Given this list of marker genes THRA, VDR, NR2C2, NR6A1, ESRRA, NR2E3, HNF4A, here is a description of the gene set: Nuclear receptors whose expression correlated with that of aromatase (CYP19A1) in a panel of breast cancer biopsies. species: Homo sapiens Human Gene Set: MIKI_COEXPRESSED_WITH_CYP19A1 Aromatase is a key enzyme in intratumoral estrogen production required for the production of estrogens through the conversion of serum androgens in postmenopausal breast cancer patients. There have been, however, controversies regarding the intratumoral localization of aromatase in human breast carcinoma tissues. Therefore, we have first examined the intratumoral localization of aromatase mRNA/protein in 19 breast carcinomas using laser capture microdissection/quantitative reverse transcription-PCR (RT-PCR) and immunohistochemistry. Aromatase mRNA and protein were detected in both intratumoral stromal and parenchymal cells in breast carcinoma tissues. Subsequent microarray expression profiling and clustering analyses, in addition to quantitative RT-PCR studies, showed a significant positive correlation between aromatase and estrogen-related receptor alpha mRNA expression in isolated carcinoma cells. We further examined an interaction between stromal cells isolated from human breast carcinoma tissues and breast carcinoma cell lines using a coculture system to study the biological characteristic of aromatase expression in carcinoma cells. Aromatase mRNA and enzyme activity and 17beta-hydroxysteroid dehydrogenase type 1 mRNA in breast carcinoma cell lines, including MCF-7 and SK-BR-3 cells, were up-regulated in the presence of patient-derived 32N or 74T intratumoral stromal cells. The results from steroid conversion assays were also consistent with the findings above. The results of our study also showed that aromatase inhibitors were more effective in inhibiting aromatization induced by coculture in MCF-7 than that in stromal 32N. The examination of the localization of aromatase and its regulation, including the interactions existing between different cell types in human breast carcinoma tissues, may provide important information as to achieving better clinical response to aromatase inhibitors in breast cancer patients. from publication Miki Y, Suzuki T, Tazawa C, Yamaguchi Y, Kitada K, Honma S, Moriya T, Hirakawa H, Evans DB, Hayashi S, Ohuchi N, Sasano H (PMID 17440110)